Given this list of marker genes RPL29, PRMT5, TM7SF3, ARHGAP15, KLHDC2 (NCBI Gene Id 23588), THUMPD3-AS1, LIN28B, GADD45B, GFRA3, ZMIZ1, ZNF296, DPP9, NGLY1, RPL26, ID3, MAML3, H2AZ1-DT, MYNN, ZBTB4, HSPE1, RPL12, FGF19, PNP, SSBL4P, KMT2A, ALDH1A2, EXOC4, RNPS1, EXOSC4, HEXIM2-AS1, ZNF76, RPS9, CDH2, PAM, H2AZ1, PRDM1, CDC27, COX17P1, ACTG1, DNAJB4 (DnaJ heat shock protein family (Hsp40) member B4, NCBI Gene Id 11080), KIF9, RUNX1, TLE3, ASCC1, CTSA, BLOC1S1, PHF12, RPL18, ELF1, AP2S1, RPL10A, DUSP6, SAE1, SNORD49A, RPS27, CCND1, POLG-DT, MIR5087, SLC30A10, SMARCD2, SACM1L, THAP11, AFF1, DET1, TMED10, SETD5, RPL17, CABLES1, ZBTB40, RPL11, TRIM36, FBXL19, H3C10, ZNF639, NUFIP2, CRYZ, LDHA, PRPH, LINC02918, EEF2, ITGA7, ZC3H4, SNHG5, SNHG12, H2AC21, SS18, NOLC1, GALNTL5, ENSG00000232995, DMD, MPND, SMAD6, CNTNAP2, MCM4, HNRNPR (heterogeneous nuclear ribonucleoprotein R), POLD3, CBX5, H2BC21, VPS37B, PIPOX, SRBD1, SGMS1-AS1, KRR1 (NCBI Gene Id 11103), IL4I1, ARID4A, GLUD1P3, PDE4A, TBL1X, ZNF484, HDAC2, BDNF-AS, GBA1, CHCHD5, G6PC3, LAMP1, ENSG00000228044, XPO1, AP3S1, AKT1S1, VPS29, RPL5, CALM2, PTPMT1, SPHK2, RRM2, PRPF6, ZNF615, EIF3B, RNA5SP213, ZNF146, SNORD68, FBXO28, CAPZA2, RPS14, LPIN1, LRSAM1, NDUFA4, MYL11, H3-3B, RN7SL2, GNG12-AS1, NDUFS3, PER1, HEXIM2, PPP3R1, MIR7-3HG, ID2, MALAT1, NOL8, HSPD1, GRK4, COX7A2, AKR1A1, ACSL3 (acyl-CoA synthetase long chain family member 3), ITSN1, KCNK1, UFSP2, ADM (NCBI Gene Id 133), RRP8, NOP14, LZIC, MAN2C1, HEMK1, VTRNA1-3 (NCBI Gene Id 56662), HTR5A, DALRD3, CADM1, VTRNA1-1, MAP2K7, NEK2, RBM43, DDX46, OXSM, MAGI1, METTL25, SRSF3, COQ5, ALG8, HDGF, PTPN1, DGAT2, CASZ1, SNRNP70, HBB, ERI1, HYOU1, RANBP3, RPS12P7, NEUROG1, RPL7L1, UBAP2L, MRPL1, YBX1, TTC9C, LINC01623, CDC25C, PRDX1, GLRA1, DDX23, EZH2, LAPTM4B, ZNF24, RNA5SP60, NR1D2, SDE2, HEXA, PIK3R3, ILF2, MED23, MRPS18B, PRKDC, VPS52, SCNM1, LUC7L2, ZNF644, POLG, ALDH4A1, HAUS8, MRPS15, USP54, PRUNE2, LIN7C, POU2F1, POU2F1-DT, RPS15, RPL35, PNRC2, RPL15, LINC02832, UFD1 (ubiquitin recognition factor in ER associated degradation 1), CFAP96, EMC3-AS1, HOXA1, GRM1, CFAP418, TOB1-AS1, TPH2, H4C5, ZNF565, PHLDA1-DT, SNORD46, PRPF38A, ZBTB37, DHDDS, MRPL53 (NCBI Gene Id 116540), TSR3, TPI1, SENP6, PAMR1, TPRA1, TBC1D5, CCNC, DDX42 (DEAD-box helicase 42), RPL3, RPLP0, MRPS24, G3BP2, EYA3, POLR3G, NSMCE2, SNHG3, HMGN4, LINC01719 (NCBI Gene Id 101928979), RPL31, AKIRIN2, TNPO1, MYO9B, ILRUN, SCGN, LTV1, PPEF1, TMEM94, EIF4A2, PTBP1, TBC1D17, CHASERR, NDUFB2, CDIP1, STAT1, CNOT9, PPP1R10, MIR615, ATXN1L, H4C4, FUS, MGST3, SNHG25, PDHB, MID1 (midline 1), QTRT1, CEP128, TRIT1, PHLDA1, PAX6, PKM, MAN1C1, FAM135A, RFTN1, ARPC5L, CRADD, SNORA16A, IER3-AS1, SNORD43, RPL13, MAPK4, ENPP3, TTC19, TTLL7, SAMD10, BOLA1, IST1, RAB7A, ZNF649, SNORD60, RPL38, FEM1A, GPATCH4, MFSD11, BMS1P4-AGAP5, TRMT1, RPS24, PRKAG1, TTC4, TPM3 (NCBI Gene Id 91191), GAS5, TPGS1, FUBP1, BLOC1S5, MDC1, IPO13, CCDC59, PABPC1, SNX8, NOP53, SNORD101, ARID1A, SCARNA2, FGD6, STAP2, HDDC3, HSPE1-MOB4 (NCBI Gene Id 100529241), PEPD, MAT2A, HEXA-AS1, SNRPB, DNMT1, SNX12, NDUFA7, HES1, TMEM243, ENSG00000224865, ENSG00000272195, ZNF608, RPL4, IER2, SNHG19 (NCBI Gene Id 100507303), NAV2-AS4, KIAA0319, KLHL18, CNPY2, MIR7-3, NKAIN1, WDR74, PKIA, KCTD3 (potassium channel tetramerization domain containing 3), INSM1, SVOP, FHL1P1, CAPS2-AS1 (NCBI Gene Id 101928157), RANBP3-DT, STX18, H2BC5, HOXA9, RGS16, MRPS10P1, HSP90AA1, NRAV, CENPT, BCAR3, ELP2, COMMD6, GUSBP11, PYGO2-AS1, BARHL1, TPM1, SCYL3, GSPT1, SPRY2, H2AC25, DYNLL1, RPS12, AGPAT3, FLOT1, USP37, RFX1, LIN9, MIR191, GLUL, SNORD104, RPS4X, TRMT13, SSR1, AP3M2, SASS6, SNAP25-AS1, PPIL4, GTF3C3, CENPP (centromere protein P), TOMM40L, PLEKHG2, ENC1, MT-TF, NKIRAS1, UBE2D3, CSTB, SLC4A2, HINT3, PCBP2, NMNAT1, MCIDAS, HNRNPH3, NRP2, RPS8, HNRNPA1, CXXC1, BABAM1, LEMD2, PRMT5-DT, GTF2IRD1P1, PRCC (proline rich mitotic checkpoint control factor), H2AX, LATS1, STRIP1, SNHG17, MAFB, ALOXE3, LINC02609, MRPS23, GLI3, BLOC1S5-TXNDC5, TEF, GPC5-AS1 (NCBI Gene Id 100873969), RPL6, LINC01962, EVI5, DOC2A, IMPACT (impact RWD domain protein), ADGRB3, RPL32, RCN1, UQCRH, LGR4, RPS12P5, DCAF8-DT, TNK2-AS1, AGBL5-AS1, EEF1G, H2BC26, CCBE1, LIMD1-AS1 (LIMD1 antisense RNA 1), CDK5, TUBB4B, HOXB8, SFTA3 (NCBI Gene Id 253970), SLC39A6, NKX2-5, RNVU1-14, EMC3, DGAT1, TRIM7-AS2 (TRIM7 antisense RNA 2), ARMH4, MTHFD2, CITED2, HOXB5, EFCAB14, PTCD2, EPB41L4A-AS1, MRPL24, CCT3 (chaperonin containing TCP1 subunit 3), GSTCD, SLX4IP, UTS2, RPL36P5, WWP2, COX20P1, SF3B3, SECTM1, RPS15A, GAPDH, C1orf43, SPAST, TRDMT1 (tRNA aspartic acid methyltransferase 1), MTUS1, SNX5, COX7C, SRRM1, SEC62, PYGO2, SAMD11, IFRD1 (NCBI Gene Id 95049), NOM1, TRIM67, ATF5, MRPS27, SLC9A1, NUF2, RNF168, KAZALD1, TMEM250, IER5, UMPS (NCBI Gene Id 7372), SF3A3, POLR2A, NSG2 (NCBI Gene Id 51617), FBXO31, DOLPP1, NXF1, INTS12, TBC1D10B, MKX, SNORD49B, SNHG29, CALM1, RPS17, MT-RNR1, SHB, MGME1, GEMIN6, PSMA1, BMAL1, PPP6R3, CHD2, RPL41, HNRNPUL2-BSCL2 (NCBI Gene Id 100534595), ZC3H10, MNT, HECTD1, HNRNPUL2, OTX1, MAP1LC3B, HSPA1B, LINC02593, SLC1A5, KNTC1, LINC03000, PLD6, DDX3X, PEX3, C18orf21, STK11IP, NFIB, PKNOX1, PRSS23, KDELR1, HNRNPF, LINC00240, SNORA50C, LINC00382, ATOH1, FLCN, NUDT2, ENO1-AS1, PPP1R9A, RPL39P40, HNRNPD, OGDHL, RSRC2, HOXD11, SNORD55, AGBL5, SNORD50B, FOXO3, DYNC1I2, SRRM3, MIR3677HG, REPIN1, NASP, RAB11A, NPTN, PPM1K, NFYC, FOXJ3, PRR14, ZNF629, MALRD1, CDK17, SRSF7, TRMT12, TRIM41, RPS6, MAZ, XIST, PDE4B, SRSF2, LINC01780, HSPH1, SNORD15A, HOXA-AS3, EIF5, HOTAIRM1, CDC45 (NCBI Gene Id 8319, cell division cycle 45), RNU2-63P, ZC3H15 (NCBI Gene Id 55854), VGF, PDE4D (phosphodiesterase 4D), LINC02136, ISG15, RPL17-C18orf32, RGS5, S100A10, ORC1, ID2-AS1, NEURL2, BMS1P4, TLE6, USP9X, VEZT, TRAF7, ATP6V1G1, ZFP37, SNORA7A, HSP90AB1, STAT3, CYB5R4, ILK, HES4, KAT6A, GIPC2, PCDH9, SGK3, P4HB, TLE4, CLPB (ClpB family mitochondrial disaggregase), RPS28, GREB1L, UBB, RNU6-1109P, TXNIP, SLC39A3, RPL7, MIR9-3HG, RPL22L1, WASHC5, RPTOR, RPL9, NACA, HLA-DMA, ILRUN-AS1, HEXIM1, EHBP1, GCN1, TSACC, GATA4, LIAS, COG4, KLF11, CCT6B, TOB1, ITPR1-DT, MANBAL, RPS3, IGF2BP3, HNRNPAB, CCDC174, ADAT2, OSBPL8, CCDC124, IPO7, RNF138, ESYT1, GNPTG, B3GNT4, ELMO1, INO80C, DPH1, CISD2, LYSMD1, FAM53C, KCTD21-AS1, CLN5, SDHAF3, YIPF2, ZNF300, TIMM29, PUM1, SUMF1 (sulfatase modifying factor 1), HDAC2-AS2, ZNF350, TYW3, H2AC12, BRAF, ITPR1, MCC, TBC1D9, SGMS1, TOR1A, H4C8, RNU5A-1, ENO1, POLDIP3, GHITM, YWHAE, C5orf15 (chromosome 5 open reading frame 15), MTF2, TRAPPC3, FBXO32, PXN-AS1, LSM14A, GNRH1, ZNF585A, ULK4, RPL27A, PRAF2, SNORD58B, NDUFAF3, HMGN2, ZSWIM7 (zinc finger SWIM-type containing 7), LEF1-AS1 (NCBI Gene Id 641518), HNRNPD-DT (HNRNPD divergent transcript), ABCB8, NUP62, SNORA13, PSMA3-AS1, ZWILCH, DDIT4, TASOR, NR6A1, ARHGAP32, XPO6, ZNF775, HS3ST3A1, RAD9B, BRD2 (bromodomain containing 2), MSH6 (mutS homolog 6), RCC1, H2AC20, here is a description of the gene set: Genes containing one or more binding sites for (FOXE1) in their promoter regions (TSS -1000,+100 bp) as identified by GTRD version 20.06 ChIP-seq harmonization. Human Gene Set: FOXE1_TARGET_GENES studied in species Homo sapiens from publication Yevshin I, Sharipov R, Kolmykov S, Kondrakhin Y, Kolpakov F (PMID 30445619)